The following is a description of a gene set: species: Mus musculus Mouse Gene Set: TABULA_MURIS_SENIS_KIDNEY_EPITHELIAL_CELL_OF_PROXIMAL_TUBULE_AGEING from publication Tabula Muris Consortium (PMID 32669714), and this is the list of marker genes: Aldh9a1, Tst, Gm5617, Eif3i, Itm2b, Immp1l, Rps15, Slc25a3, Ass1, Rps29, Hint1, Rpl15, Hdgf (NCBI Gene Id 99546), Rps6, Sri (sorcin), Gas6, Id2, Srsf5, Rpl8, Grcc10, Rps12, Csrp2, Aqp1, Hcfc1r1, Rpl18, Eef1g, Rpl31-ps12, Zfp36l1, S100a11, Prdx2, Cyp24a1, Guk1, Eef1a1, Dpm3, Rpl27, Ndufb11, Nenf, Naca, Slc51b, Tmt1a, Gchfr, Bola3, Cd74 (NCBI Gene Id 16149), Mrpl33, Rps27l, Gpx4, Ndufaf8 (NCBI Gene Id 66426), Rpl39, Gas5, Wfdc2, Chchd7, Slirp, Cyb5a, Adk, Iyd, Iah1, Eif1, Srrm2, Mfsd4b5, Eif3f, Ccn1, Rpl37, Rpl24, Rpl9, Gsta3, Guca2b, Igfbp7, Ost4, Slc22a12, Tex261, Iscu, Txndc17, Slc22a29, Tstd1, Tcea3, Rpl22, Cisd1 (CDGSH iron sulfur domain 1), Nqo1, Rps15a, Laptm4b, Rpl6, Rtraf, Rps19 (NCBI Gene Id 20085), Slc13a1, Fth1, Cela1, Hao2, Tmem252, Mrpl30, Anp32a, Sptssa, Cox8a, Scd1 (stearoyl-Coenzyme A desaturase 1), Rps11, Lamtor2, Slc15a2, H2az1, Bnip3, Rer1, Cmbl, Sat1, Cd81, Rpl36a, Gstk1, Polr2e, Eef1d, Rab14, Jtb, Rpl5, Tmbim4, Rps3, Tomm6, Rdh16f2, Slc22a8, Gsta4, Gng5, Hspe1, Ube2d3, Rpl36 (NCBI Gene Id 54217), Fam162a, Rpl32, Ghr, Ifi27, Krtcap2, Camk2n1, Rps9, Bphl, Rps2, Rpl22l1, Apoe, Cbr1 (NCBI Gene Id 224441), Klf6, Npl, Rps7, Swi5, Tmem59, Apom, Rplp1, Gsr, Slc6a6, Abat, S100a10, Rplp0, Acsl1, Rps16, Rps26, Mrpl42, Fkbp2, Ndufa4, Gpx1, Naa38, Mrpl23, Rpl7, Hmgb1, Ccdc198, Eif3e, Aldh7a1, Ndufb9, Calml4, Snhg8, H1f0, Gabarap, Prlr, Dhcr24, Bhmt, Rpl10a, Tmco1, Rps27, Napsa, Gstm1, Ssr4, Rpl37a, Mien1, Bax, Mfsd4b1, Spns3 (SPNS lysolipid transporter 3, sphingosine-1-phosphate (putative)), Rnf7, Cpn1, Cuta, Mrfap1, Rpl13a, Cyp2a4, Btg2, Akr7a5, Rpl7a, Cyp2d12, Lyplal1, Jund, Hpd, Tmem19, Aldh2, Uba52, Rps27a, Hmgn1, Nop10, Gabarapl1, Gatd3a, H3f3a, Rps17, Psmg4, Hsd3b4 (hydroxy-delta-5-steroid dehydrogenase, 3 beta- and steroid delta-isomerase 4), Mgll, Dnajc12, Rpl38, Sumo2, Hint2, Rab5if, Gcdh, Fundc2, Rpl10, Rpsa, Commd3, Spsb4 (splA/ryanodine receptor domain and SOCS box containing 4), Ascc1, Prxl2a, Sumo1, Rpl19, Tpt1, Cyp4a14, Rpl35, Rps4x, Bola2, Krcc1 (lysine-rich coiled-coil 1), Cnn3, Dstn, Defb29, Gc, Anapc13, Vkorc1, Tmem256, Ncoa7, Cubn, Eif3k, Rpl12, Rpl13, Cox7b, Rps18, Pts, Rps15a-ps6, Ldha, Gstm5, Gstz1, Rps25, Rpl21 (ribosomal protein L21), Nme1, Npm1, Cox20, Apob, Npnt (NCBI Gene Id 99581), 0610005C13Rik, Rpl28, Ddt, Sephs2 (NCBI Gene Id 20768), Gstt1, Rpl11, Mrps12, H3f3b, Slc22a13, Rpl36al, Nuak2, Mpc2, Anapc11, Gsta2, Selenom, Ethe1, Dhrs4, Rnaset2b, Cfl2, Ftl1, Abracl, Med28, Cda, Rpl23, Rpl4, Rps8, Eci1, Cd302, Eef1b2, Rbm3, Mocs2, Rpl35a (ribosomal protein L35A), Rpl23a, Rplp2, Cyp4b1, Cox5a, Rps10, Atraid, Rpl31, Cox4i1 (cytochrome c oxidase subunit 4I1), Pnrc1, Fbp2, Clta, Ube2r2, Cyp4a10, Rps20, Mir703, Tmigd1, C1qbp, Tmem254, Ggact, S100a1, Pxmp2, Dhrs3, Kyat3, Mpst, Rps23, 2310039H08Rik, Rpl29, Fmc1, Mrpl52, Rpl3, Ddc, Polr1d, Car4, Rpl27a, Hnrnpa3, Hsd17b10, Rps14, Cyp2c23, Rpl18a, BC004004, Spcs1, Ppa2, Rps13, Sult1c2, Sgk1, Rpl41, Slc38a3, Pgls, Cox7a2l, Pecr (NCBI Gene Id 69711), Retsat, Sec61g, Dnajc19, Rida, Ubxn1, Akr1c21, Atp5mc2, Ddx5, Gtf2h5, Ubl5, Mgst1, Rps21, Echs1 (NCBI Gene Id 97386), Rab2a, Mpc1, Tomm20, Rps28, Pfdn5, Tmt1b, Acaa1b, St13, Rack1, Hebp1, Rps24, Tmem205, Ddrgk1, Actg1, Gsta5 (glutathione S-transferase alpha 5), Ccnd1, Ndufb6, H1f2, Btf3, Cstb, Rpl17, Cryz, Tmem37, Fau, Hibadh, Rpl14, Ndufa7, Mrps24, Oaz1, Eif3h, Dbi, Txn1, H2bc4, Cfb, Srsf3, Acot1 (NCBI Gene Id 28195), Rps3a1, Scp2, Rps5, Jun, Micos13, Mrpl34, Gemin7, B2m, Spink1, Acaa2, Ccng1, Ccdc107, Tmem147